Given this list of marker genes UGCG, WDR45, PDK4, HSD17B11, CRADD, SH3BP5 (NCBI Gene Id 9467), H1-0, RAB9A, MDFIC, KAT2B, here is a description of the gene set: Insulin and insulin-like growth factor-1 (IGF-1) act through highly homologous receptors that engage similar intracellular signaling pathways, yet these hormones serve largely distinct physiological roles in the control of metabolism and growth, respectively. In an attempt to uncover the molecular mechanisms underlying their divergent functions, we compared insulin receptor (IR) and IGF-1 receptor (IGF-1R) regulation of gene expression by microarray analysis, using 3T3-L1 cells expressing either TrkC/IR or TrkC/IGF-1R chimeric receptors to ensure the highly selective activation of each receptor tyrosine kinase. Following stimulation of the chimeric receptors for 4 h, we detected genes to be differentially regulated, of which 10 were up-regulated to a greater extent by the IGF-1R. These included genes involved in adhesion, transcription, transport, and proliferation. The expression of mRNA encoding heparin-binding epidermal growth factor-like growth factor (HB-EGF), a potent mitogen, was markedly increased by IGF-1R but not IR activation. This effect was dependent on MAPK, but not phosphatidylinositol 3-kinase, and did not require an autocrine loop through the epidermal growth factor receptor. HB-EGF mitogenic activity was detectable in the medium of 3T3-L1 preadipocytes expressing activated IGF-1R but not IR, indicating that the transcriptional response is accompanied by a parallel increase in mature HB-EGF protein. The differential abilities of the IR and IGF-1R tyrosine kinases to stimulate the synthesis and release of a growth factor may provide, at least in part, an explanation for the greater role of the IGF-1R in the control of cellular proliferation. from publication Mulligan C, Rochford J, Denyer G, Stephens R, Yeo G, Freeman T, Siddle K, O'Rahilly S (PMID 12213819) Human Gene Set: MULLIGAN_NTF3_SIGNALING_VIA_INSR_AND_IGF1R_DN species: Mus musculus Genes similarly down-regulated in 3T3-L1 cells (fibroblasts able to differentiate to adipocytes) upon stimulation of INSR or IGFR1 by NTF3.